The following is a description of a gene set: from publication Chen Y, Wang X (PMID 31504780) studied in species Mus musculus Genes predicted to be targets of miRBase v22 microRNA mmu_miR_3099_5p in miRDB v6.0 with MirTarget v4 prediction scores > 80 (high confidence targets). Mouse Gene Set: MIR_3099_5P, and this is the list of marker genes: Itpr1, Kcmf1, Cmpk2, Napa, Naa30, Dcaf7, Rnf40, Fam120a, Kpna2, Arf3, Peg10, Ythdc2, Rabgap1l, Lhfpl2, Kcna1, Ppfia2, Xirp2 (NCBI Gene Id 98983), Zc3h6, Mctp1, Mmaa, Gtf3c2, Nox4, Tmprss11f, Nbea, Fmo9, Hnrnpul2, Nell2, Cpeb1, Synrg, Grpel1, Zfp148, Camta1, Bptf, Fam133b, Cdk6, Selenof, Elk1, Csrnp3, Derl1, Hif1a, Unc50, Arhgap19, Serpini1, Celf4, Rab39, Diras2, Rab23, Pou2f1, Klhl13, Sowahb, Tbc1d15, Elavl2, Med14, Msantd4, Rngtt, Psmb2, Pcnx1, Il1b (interleukin 1 beta), Dpysl2, Naa60, Hdac9, Nfasc, Sft2d2, Prss33, Cyp2b19, Tmem201, Tirap, Tnrc6b, Bdh2, Gab2, Cdk8, Neurl4, Epg5, Slc48a1, Pwwp2a, Pfkfb2, Dipk1a, Ccdc18, AU040320, Ttc6 (tetratricopeptide repeat domain 6), Srek1, Unc5c, Acsl4, Coro2b, Clta, Fry, Ell2, Erlin2, Eif3j2, Zfp213, Acss1, Il5ra, Myt1l, Smad9 (NCBI Gene Id 55994)